The following is a description of a gene set: Genes up-regulated in macrophages (12h): IFNG, TNF and rosiglitazone versus IFNG and TNF. Human Gene Set: GSE16385_ROSIGLITAZONE_VS_UNTREATED_IFNG_TNF_STIM_MACROPHAGE_UP species: Homo sapiens from publication Szanto A, Balint BL, Nagy ZS, Barta E, Dezso B, Pap A, Szeles L, Poliska S, Oros M, Evans RM, Barak Y, Schwabe J, Nagy L (PMID 21093321) Human CD14 positive monocytes were purified from healthy volunteers’ blood and cultured in vitro for 4, 12, 24, 72 hours. While culturing, macrophages were activated alternatively with interleukin-4 (IL-4 100 ng/ml) or classically with interferon-gamma (IFNg 100 ng/ml)+tumor necrosis factor (TNF 50 ng/ml) or left without activation. Simultaneously, macrophages were also treated with vehicle (DMSO:ethanol) or 1mM synthetic PPARg agonist, Rosiglitazone. We used Affymetrix microarrays (U133Plus 2.0) to analyze activation and PPARg-induced gene expression changes., and this is the list of marker genes: IPO9, CENPN, DYNLT1, GBP6, TRAM2, PTTG1, SYNGR2, JAG1, C8orf58, RASEF, TOR1B, RMND5B, USP18, ENDOU, FGFR1OP2, IGF2BP2, KLHL14, ATP11A, ATP1B1, ZSCAN10, SLC18B1, RBM45, HCN3, SLC25A47, CMC2, SCD, IFI30, RMC1, FBLN1, SLC26A1, MDM1, PADI4, SH3BGRL2, PACRG, IRF4, ATP11B, P4HA2, CSF3, CYP3A4, CPVL, SLC44A2, ARL10, TMC7, TIMM10, RHEBL1, ATP6V0A1, EID2 (EP300 interacting inhibitor of differentiation 2), ELAC1, GLIS1, ATF7IP2, TC2N, RHOD, TUSC1, GCSH, SAMD9L, PGBD5, HS6ST2, INSL5, NOCT, NTHL1, RAB39B, OAS1 (NCBI Gene Id 4938), SLC16A2, ZC3H8, RPS6KA3, PDCD1LG2, ANKRD39, METTL6, LYL1, CD79A, MAN2A1, DOCK4 (dedicator of cytokinesis 4), DUSP6, POU2AF1, PDE4DIP, IFI27, ANXA5, MYF6, IFI27L2, COMMD4, OLIG1, PDE4B, ELAVL4, C14orf28, TAFA3 (NCBI Gene Id 284467), EEIG2, CEP170B, MGAT5, CXCR4, RAB3GAP1, CLDN16, CD52, HAS2, UGGT1, GLIS2, NKX2-6, CCKAR, GJA4, NMNAT1, TUFT1, GUCY2C, ADAM32, RBP7, THSD1, IFFO2, STON1, CSRP1, P2RX4 (NCBI Gene Id 5025), PAFAH2, STK24, IGFBP5, GLB1L3, CCL5, TXNDC2, CYBB, MYO1B, FBXO42, TMEM181, AQP12A, GALNT4, EFCAB7, SH3BGR, SMIM12, PNMA1, GRK3, AGPS, TMEM267, CD38, TEX36, IGLC7, UQCRQ, SLC41A1, IL18, UBXN11, PIGS, BLNK, SEPTIN10, GGT7, MS4A1, PSMB9, ATP13A2, FREM2, KIF15, ATMIN, OMD, RILP, ZCWPW2, LDAF1, PLEKHF1, KAT6A, CEP70, TIRAP, TXN, TSR1, MOB3A, PDGFD, SLC30A4, MYLIP, TRIB3, NIBAN3, OLIG3, THBD, PPP1R3B, SETD4 (SET domain containing 4), CECR2, PKD2L2, CPSF6, CAPRIN2, KCTD8, RAP1B, SERPINA1, ALOX12, NUMBL, SLITRK5, RPP25, RCBTB2, SGSM2, NIPBL, DNTT, B2M, CTSE, TXNIP, UNC13D, CASS4, MYOD1, DNAAF9, LRRC73, SQOR, CTSV, SLIT3, NSG1, PARD6B, CPM, GAL3ST2, LTK, SLC35B4, BMF, DNASE1L3, MAP3K9, NUDT12